Given this list of marker genes IGLL1, SEPTIN7, VPS11 (VPS11 core subunit of CORVET and HOPS complexes), FGFR2, HSPB2, MEG3, OTUD5, PICK1, PTHLH, BCO2, ARHGAP33, UPB1, CRYBB3, PDE4DIP, GLRA3, NKX2-1, CBFA2T2, PDGFRA, POM121, MSRA, SLC36A1, ODAD3, GLG1, CD6, RUNX1, L1CAM, SH3D19, AGPAT3, GDPD2, PKD1P1, HOXC6, here is a description of the gene set: from publication McCabe CD, Spyropoulos DD, Martin D, Moreno CS (PMID 18339881) Genes whose promoters were bound by HOXC6 in LNCaP cells (prostate cancer) and which were up-regulated in comparison of tumor vs normal prostate tissue samples. Human Gene Set: MCCABE_HOXC6_TARGETS_CANCER_UP species: Homo sapiens Homeobox transcription factors are developmentally regulated genes that play crucial roles in tissue patterning. Homeobox C6 (HOXC6) is overexpressed in prostate cancers and correlated with cancer progression, but the downstream targets of HOXC6 are largely unknown. We have performed genome-wide localization analysis to identify promoters bound by HOXC6 in prostate cancer cells. This analysis identified 468 reproducibly bound promoters whose associated genes are involved in functions such as cell proliferation and apoptosis. We have complemented these data with expression profiling of prostates from mice with homozygous disruption of the Hoxc6 gene to identify 31 direct regulatory target genes of HOXC6. We show that HOXC6 directly regulates expression of bone morphogenic protein 7, fibroblast growth factor receptor 2, insulin-like growth factor binding protein 3, and platelet-derived growth factor receptor alpha (PDGFRA) in prostate cells and indirectly influences the Notch and Wnt signaling pathways in vivo. We further show that inhibition of PDGFRA reduces proliferation of prostate cancer cells, and that overexpression of HOXC6 can overcome the effects of PDGFRA inhibition. HOXC6 regulates genes with both oncogenic and tumor suppressor activities as well as several genes such as CD44 that are important for prostate branching morphogenesis and metastasis to the bone microenvironment.